The following is a description of a gene set: Human CD14 positive monocytes were purified from healthy volunteers’ blood and cultured in vitro for 4, 12, 24, 72 hours. While culturing, macrophages were activated alternatively with interleukin-4 (IL-4 100 ng/ml) or classically with interferon-gamma (IFNg 100 ng/ml)+tumor necrosis factor (TNF 50 ng/ml) or left without activation. Simultaneously, macrophages were also treated with vehicle (DMSO:ethanol) or 1mM synthetic PPARg agonist, Rosiglitazone. We used Affymetrix microarrays (U133Plus 2.0) to analyze activation and PPARg-induced gene expression changes. studied in species Homo sapiens Genes down-regulated in macrophages (12h): IFNG, TNF and rosiglitazone versus IL4. Human Gene Set: GSE16385_ROSIGLITAZONE_IFNG_TNF_VS_IL4_STIM_MACROPHAGE_DN from publication Szanto A, Balint BL, Nagy ZS, Barta E, Dezso B, Pap A, Szeles L, Poliska S, Oros M, Evans RM, Barak Y, Schwabe J, Nagy L (PMID 21093321), and this is the list of marker genes: SRP54, COL5A3, UNC45A, FRA10AC1, NDST2, CRYZ, ASPG, NUP43, METTL6, RCOR3, DMAC2L, NKRF, ARL15, RASGEF1C, MEGF9, TNFRSF21, LTF (NCBI Gene Id 4057), ANKRD12, ERMARD (ER membrane associated RNA degradation), CD14, CLU, RAD17, NOL12, ACOX1 (NCBI Gene Id 8308), DYM, DRAM1, ORC5, TXNDC17, MAPK1, GRAMD2B, CCDC66, GJA1, IFT70B, SEPHS2, SCFD1, KCTD4, CNEP1R1, LNX1, GUCY2D, MZT2B, PRRT3, TRDMT1, OSTC, MAPK8, RNF113A, ANKRD10, SLCO3A1, TMEM252 (NCBI Gene Id 169693), EHD1, CCDC91, NIN, HSPA4L, IK (IK cytokine), ZNF518A, JARID2, SLC2A9, DCAF17, EPC1, CRYZL1, MID1, MFSD14A (major facilitator superfamily domain containing 14A), EREG, CREB3L2, ASAH2, MAP4K3, MORC3, RIMOC1, AMMECR1L, IFIH1, PELI2, RNF14, GNL2, CCDC90B, SHROOM4, BBS10, HPSE, UQCRC2, CNKSR3, PRSS45P, SLC6A12, DNAJA2, CUTC, CCDC28A, IGF2BP1, SLC24A3, SCN2A, MPP1, TPP1, RASGRP2, FASLG, RABEP2, CLEC1B, EOLA1, P2RX1, NHERF4, SLC30A6, KLHL12, TNFAIP6, GPRASP3, XCL1, PRTN3, E2F5, PIP5K1B, SGCE, HRG, MMP24, ZNF330 (NCBI Gene Id 94900), CDIN1, PTGIR, SELENOS, DIAPH2, RBBP4, SASH1, OTOS, ZNF469 (zinc finger protein 469), LARP4B, CS, CDCA7L, ALDH6A1, SERPINB1, VDAC3, LAMTOR3, SETDB2, SCARF1, SHISA4, LTBP3, POT1, COL4A3, KBTBD4, TMT1A, SPRY2, SCP2, GTDC1, MSR1, GPD1L (glycerol-3-phosphate dehydrogenase 1 like), PORCN, MTF1 (NCBI Gene Id 4520), RPRD2, H3C7 (NCBI Gene Id 8968), CHST11, LZTR1, SESTD1, SNIP1, GNAI3, PPP2R5A, GALC, CDC42BPG, PECR, SECISBP2, TAMALIN, WDR43, FAH, AKR1B1, DMKN, THNSL1, MORF4L1, GMFG, UBXN2A, EPHA8, GGNBP2, SUSD1, DTX3, DEPTOR, FNTA, RAPGEF2, FAM171A1, PRXL2A (peroxiredoxin like 2A), C5orf24, CSGALNACT1, APPL2, DOCK5, IQGAP1 (NCBI Gene Id 8826), GPRASP1, WDR7, RPIA, WDR75, TNFAIP2, TF, SON, PPP1CC, CERS4, GALM, XBP1, KLHDC2, GRK5, POLR2G, PTGR1, OGA, CA1, TBCE, BBS9, UTP11, DLG1 (NCBI Gene Id 1739), SNX31, SLC18A2, BBS4, ATP6AP2, TNNI3, FBXO16, MCF2L